Given this list of marker genes COL1A1, ZBTB20, DKK1, COL1A2, NOTCH2, here is a description of the gene set: Basilar impression species: Homo sapiens Abnormal elevation of the floor of the posterior fossa including occipital condyles and foramen magnum. Human Gene Set: HP_BASILAR_IMPRESSION